Given this list of marker genes Hmgb1, Clec12a, Tmem176a, Ager, Cd40lg, Tmem176b, Zbtb46, Cebpb, H2-M3, here is a description of the gene set: Mouse Gene Set: GOBP_REGULATION_OF_DENDRITIC_CELL_DIFFERENTIATION species: Mus musculus Any process that modulates the frequency, rate or extent of dendritic cell differentiation.